The following is a description of a gene set: Human Gene Set: GSE33374_CD8_ALPHAALPHA_VS_ALPHABETA_CD161_HIGH_TCELL_UP We used microarrays to compare gene expression between healthy human CD161++CD8aa and CD161++CD8ab T cells. Genes up-regulated in KLRB1 high T cells: CD8A versus CD8A CD8B. species: Homo sapiens from publication Walker LJ, Kang YH, Smith MO, Tharmalingham H, Ramamurthy N, Fleming VM, Sahgal N, Leslie A, Oo Y, Geremia A, Scriba TJ, Hanekom WA, Lauer GM, Lantz O, Adams DH, Powrie F, Barnes E, Klenerman P (PMID 22086415), and this is the list of marker genes: PLAC9, COMMD9, CD4, AKAP1, ATP13A1, SELL, PTPN23, H2BC14, CD8B, ZNF213, CEL, CD79A, MED27, PTPRK, CCDC28B, KLF1, IRF3, GRAP2, GPR37L1, MYBBP1A, PIK3C2A, SMPD2, DEGS2, DIAPH3, CD8A, LIG3, SULT2B1, ZBTB7B, USP3, PRKCZ, BCL7B, NR1H2, SGF29, WNT7A, NAA80, GGT5, B4GALT3, FGF10, IGFBP6, FUT4, NKIRAS2, TNNC2, BCL3, RUNDC3A, KCNB1, STRN4, ACKR1, GSTM3, TRPC4, ANAPC15, PLBD1, MYBL2, MRPL41, TNFRSF8, DAPK3, KPNA6, CRYBA1, PDXK, COL6A1, CCR7, PTGER1, CCL19, BRAF, LYST, ELP5, CNTNAP1, MEIS2, SMARCD1, FGF1, TSPYL1, MMP24, ARL4C, ESRRB, PDX1, HRH1, ANGPTL2, SDSL, KCNH2, CBFA2T3, EHD1, FEM1A, SF3A2, AFF1, CUX2, CD6, NHSL2, CIT, MRPL55, SLC25A19, ACIN1, ADORA2B, ZNF385A, KRT7, APOF, SSC4D, PEMT, CKM, B3GALT4, APLNR, LECT2, SNX17, H2AJ, SHD, ACY1, CELSR1, RAI1, DRC1, GDNF (NCBI Gene Id 2668), IL4R, GNA11, RNF167, COL7A1, NKAIN1, MPDZ, ATOX1, SETD4, C8G, TRH, NOTCH1, ALOX15, FOXO4, HDAC7, TGFB1, NEURL4, PLEKHH1 (pleckstrin homology, MyTH4 and FERM domain containing H1), PRKD2, GNAQ, CDK5R2, SOCS3, NMT2, PRAF2, ACTN2 (NCBI Gene Id 88), RFLNB, ATRX, FOXN3, TFPT, DDR2, MAP3K12, XRCC1, PITX1, PCID2, RGS11, HCN3, RXRA, COL18A1, COQ4, DNTT, HS3ST3A1, NCAM1, RAB25, DAGLB, CIC, CD74, EXO1 (exonuclease 1), ST6GALNAC1, STAT5B (signal transducer and activator of transcription 5B), IL12A, NPPA, ATF5, IL18, LHX6, EXOSC8, DLG3, DHODH, MKNK1, HOXA4, KRT27, NRSN1, FGF3, SLC26A1, UQCRQ, LTBP1, LMO2, BMP4, UTF1, ANGPT2, GFRA3, NUCB2, NPAS1, CD2, HOXD13, SHBG, SIM1, LCOR, EFNA2, GUCY2D, SNCA, ZSCAN12, HCN2, SEMA5B, IMMT, TULP3, C1QC, VCAN, SRC, SKIC2, CYP2S1, SIT1, COL1A2